The following is a description of a gene set: Any process that activates or increases the frequency, rate, or extent of cell-cell adhesion mediated by integrin. Human Gene Set: GOBP_POSITIVE_REGULATION_OF_CELL_CELL_ADHESION_MEDIATED_BY_INTEGRIN studied in species Homo sapiens, and this is the list of marker genes: PODXL, CXCL13, CD3E, PIEZO1, SKAP1, CCL5